Given this list of marker genes Snapc3 (NCBI Gene Id 77634), Snapc1, Gtf2f2, Gtf2f1, Taf11, Ints2, Polr2k, Ice2, Ints13, Polr2a, Pou2f1, Srrt, Gtf2a1, Tbp, Polr2f, Ints14, Taf6, Rpap2, Taf13, Ints10, Taf8, Polr2i, Pou2f2, Gtf2b, Taf5, Supt5, Nabp2, Polr2c, Ints7, Gtf2e2, Ints8, Polr2b, Ints1, Gtf2e1, Polr2l, Polr2e, Ell2, Supt4a, here is a description of the gene set: electronically inferred by orthology from the curated human pathway This event has been computationally inferred from an event that has been demonstrated in another species.<p>The inference is based on the homology mapping from PANTHER. Briefly, reactions for which all involved PhysicalEntities (in input, output and catalyst) have a mapped orthologue/paralogue (for complexes at least 75% of components must have a mapping) are inferred to the other species. part of: RNA Polymerase II Transcription species: Mus musculus Reactome Pathway: RNA polymerase II transcribes snRNA genes